The following is a description of a gene set: species: Mus musculus p38MAPK events Mouse Gene Set: REACTOME_P38MAPK_EVENTS, and this is the list of marker genes: Kras, Mapk14, Mapkapk2, Hras, Mapkapk3, Mapk11, Ralgds